Given this list of marker genes LMNB1, FBXW11, DCTN1, NUDC, TACC1, TLK2, TACC2, CDK9, PAFAH1B1, SUN2, LMNB2, TMEM201, MYH10, SYNE3, SLIT1, SIRT1, CLMN, LMNA, KIF25, TRIM58, DYNC1H1, CEP120, PCM1, NTN1, SYNE2, SUN1, CDC42, HOOK3, CAV3, FHOD1, NHERF1, TACC3, DOCK7, here is a description of the gene set: Human Gene Set: GOBP_NUCLEUS_LOCALIZATION species: Homo sapiens Any process in which the nucleus is transported to, and/or maintained in, a specific location within the cell.